The following is a description of a gene set: Transcription of E2F targets under negative control by DREAM complex studied in species Homo sapiens Human Gene Set: REACTOME_TRANSCRIPTION_OF_E2F_TARGETS_UNDER_NEGATIVE_CONTROL_BY_DREAM_COMPLEX, and this is the list of marker genes: E2F4, LIN37, LIN9, TFDP2, E2F5, E2F1, LIN52, CDC25A, RBBP4, MAX, CDC6, TFDP1, HDAC1, MYC, LIN54, RBL1, TOP2A, RBL2, PCNA